The following is a description of a gene set: species: Mus musculus Mouse Gene Set: ZFP933_TARGET_GENES from publication Yevshin I, Sharipov R, Kolmykov S, Kondrakhin Y, Kolpakov F (PMID 30445619) Genes containing one or more binding sites for (Zfp933) in their promoter regions (TSS -1000,+100 bp) as identified by GTRD version 20.06 ChIP-seq harmonization., and this is the list of marker genes: Banp, Itpr2, Hsp90aa1, Pitpnm2, Foxn3, H2-M5, Rabepk, Sptan1 (NCBI Gene Id 76356), Gm22935, Gm14095, Fam193b (NCBI Gene Id 212483), Dhtkd1, Nrbp1, Mcf2l, Sspn, Tmc4, Lims1, Myo15a, Pdpr, Gm15779, Ccl7, Haus5, Btbd19, Slc38a8, Faiml, Ahcyl1, Papss2, Gcnt7, Hmg20b, Plcb2, Tmed2, Ube2f, Hhip, Gm4847, Ubd, Rsph14, Senp6, Crot, Gm16096, Hsp90ab1, Cfap74, Trp53cor1, Gm19705, Zwilch, Inpp5k, Fxr2, Fkbp8, Gm28874, F930017D23Rik, Gm12803, Or6n1 (NCBI Gene Id 258717), Gm25918, Gm26070, Il23a, Hspa8, 6430548M08Rik, Gm24461, Dnaaf9, Csn1s2b (casein alpha s2-like B), Rpa2, Gm12740, Gm6491, Ptges3, Zfp207, Meg3